Given this list of marker genes ENPP4 (ectonucleotide pyrophosphatase/phosphodiesterase 4), XDH, APOBEC3G (NCBI Gene Id 80065), APOBEC3C, CDA, CDADC1, MAPDA, DCTD, UPP2, AICDA, ADA, ADA2, UPP1, PNP, here is a description of the gene set: species: Homo sapiens Human Gene Set: GOBP_RIBONUCLEOSIDE_CATABOLIC_PROCESS The chemical reactions and pathways resulting in the breakdown of any ribonucleoside, a nucleoside in which purine or pyrimidine base is linked to a ribose (beta-D-ribofuranose) molecule.